The following is a description of a gene set: studied in species Homo sapiens Human Gene Set: ROSS_AML_WITH_PML_RARA_FUSION from publication Ross ME, Mahfouz R, Onciu M, Liu HC, Zhou X, Song G, Shurtleff SA, Pounds S, Cheng C, Ma J, Ribeiro RC, Rubnitz JE, Girtman K, Williams WK, Raimondi SC, Liang DC, Shih LY, Pui CH, Downing JR (PMID 15226186) Top 100 probe sets for pediatric acute myeloid leukemia (AML) subtype t(15;17): has PML RARA fusion. Contemporary treatment of pediatric acute myeloid leukemia (AML) requires the assignment of patients to specific risk groups. To explore whether expression profiling of leukemic blasts could accurately distinguish between the known risk groups of AML, we analyzed 130 pediatric and 20 adult AML diagnostic bone marrow or peripheral blood samples using the Affymetrix U133A microarray. Class discriminating genes were identified for each of the major prognostic subtypes of pediatric AML, including t(15;17), t(8;21), inv(16), MLL chimeric fusion genes, and cases classified as FAB-M7. When subsets of these genes were used in supervised learning algorithms, an overall classification accuracy of more than 93% was achieved. Moreover, we were able to use the expression signatures generated from the pediatric samples to accurately classify adult de novo AMLs with the same genetic lesions. The class discriminating genes also provided novel insights into the molecular pathobiology of these leukemias. Finally, using a combined pediatric data set of 130 AMLs and 137 acute lymphoblastic leukemias, we identified an expression signature for cases with MLL chimeric fusion genes irrespective of lineage. Surprisingly, AMLs containing partial tandem duplications of MLL failed to cluster with MLL chimeric fusion gene cases, suggesting a significant difference in their underlying mechanism of transformation., and this is the list of marker genes: FNDC3B, ALCAM, PGBD5, LTK (NCBI Gene Id 4058), LDLRAD4, MRC2, SMARCD3, CST7, CERS4, GCNT1, ARHGAP4, ARFGEF1, ASNS (asparagine synthetase (glutamine-hydrolyzing)), CALR, AUTS2, DENND10P1, TLE1, HYOU1, PRODH, MST1P2, COL2A1, CHN2, CMAHP, MANF, MPO, LRFN4, GRB10, ITPR2, PXDN, FGF13, HGF, SEC31A, CDKN1C, P4HB, GALNS, RCN1, CLMN, CTSW, MAP1A, TMEM94, RASL12, MMP2, MTARC2, CHPF2, NDST2, ST3GAL6, IGFBP2, JAG1, SLC1A4, MEG3, AQP3, CFD, PTGDS, PDE3B, HSPA5, S100B, AGAP4, TMEM87A, AGRN, MAP4, PRR14, SERPING1, ANKFY1, MEGF6, MXRA7, ANXA8, KRT18, NISCH, CCNA1, TMX4, ATG13, MST1, ALOX5, AFF2, CPA3, SLC25A38, NAALADL1, STXBP1, STAB1, TNFRSF4